Given this list of marker genes Pnoc, Ccl6, Agtr1a, Chrm1, Htr2a, Kiss1r, Edn2, Pomc, Chrm2 (NCBI Gene Id 243764), Cxcl13 (NCBI Gene Id 70783), Npb, P2ry6, Sstr3, Hcar1, Gpr143, Chrm5, Gpr65, Chrm4, Rxfp1, Opn5, Lpar4, Mtnr1b, Ltb4r1, Cysltr1, Fshr, Drd1, Oprl1, Npy1r, Rln3, P2ry13, Mc5r, Taar9, Qrfp, Ffar2, Ednrb, Adrb1, Adra2a, Ccrl2, Uts2r, Hrh2, Brs3, Nln, Ntsr1, Htr2c, Ppbp, Gpr37l1, F2r, Gpr35, Avpr1a, C5ar2 (complement component 5a receptor 2), Mc3r, Galr3, Qrfprl, Lpar5, Galr1, Rgr (NCBI Gene Id 57811), Cga, Cckbr, Cxcr4, Bdkrb1, Ccl3, Cxcl5, Oprk1, Gpr68, Psap, Xcl1, Oprm1, F2rl3, Tshr, Ptgfr, Ptger1, Lpar6, Gpr183, Pdyn, Trhr, Ptgdr2, Nmur1 (NCBI Gene Id 14767), Htr4, Gpr17, Oprd1, Mc4r, Npy2r, Tbxa2r, Sst, Cnr2, Xcr1, Ece2, Hcrtr2, P2ry2 (NCBI Gene Id 18442), Ptgir, Tac1, Sstr2, Drd4, Pf4, Ccr10, Opn3, Hrh1, Kng2, Tacr1, Ccl1, Ccl4, Grp, Hrh4, Cxcr5 (C-X-C motif chemokine receptor 5), Gpr18, Adra1d, Ltb4r2, Lhb, Hebp1, Prlh, Cxcr1, Ccl11, Npff, Npffr1, S1pr1, Rrh, Npsr1 (neuropeptide S receptor 1), Gpr31b, Htr1a, Ptger3, Tacr3, F2rl1, Adra2c, Gpr132, F2, Ccl17, Ccl21f, Avpr1b, P2ry1 (NCBI Gene Id 18441), Ccr5, Npffr2, Ccr6, Ptger4, Adra1a, Ccl25, Rho, Oxt, Bdkrb2, Lpar1, Grpr, Xk, App, F2rl2, Mtnr1a, Ccl9, Taar8b, Agtr2, Mc2r, Plppr5, Npy4r, Fpr-rs4, Insl3, Adora2b, Ccl27b, Prlhr, Edn1, Cxcr6, Taar1, Sucnr1, Hcar2, Adora3, Cxcr3 (NCBI Gene Id 12766), Opn1sw, Ccl21e, Plppr2, Avp, Kiss1, Mchr1, Ptger2, Tac2, Cnr1, Cxcl1, Prokr2, Drd5, Plppr1, Cxcl12, Ffar1, Npbwr1, Sstr1, Hc, Tacr2, Ppy, P2ry4, Lhcgr, Kel, Cx3cr1, S1pr5, Fpr-rs3, Ccl5, Htr2b, P2ry14, Ackr2, Fpr3, Cxcl2, Pyy, Cx3cl1, Gpr39, P2ry12, Adra1b, Aplnr, Gpbar1, Ptafr, Drd2, Sstr5, S1pr2, Hcrt, Nps, Cxcl9, Cckar, Ntsr2, Pmch, Ccl22, Fpr-rs6, Adrb2, Tshb, C3ar1 (NCBI Gene Id 12267), Uts2, Ccl27a, Mc1r, Ccl12, Ccl19, Gal, Htr7, Prok2, Gnrhr, Nmu, Taar8c, Apln, Oxgr1, Avpr2, Cxcr2, Nmb, Adora1, Lpar2 (lysophosphatidic acid receptor 2), Prokr1, Gpr37, Drd3, Plppr4, Uts2b, Gper1, Taar2, Ackr3, Npw, Cort, Rxfp3, Ackr4, Htr1b, Hrh3 (histamine receptor H3), Agt, Ccr9, Rxfp4, Ccr7, Plppr3, Ffar3, Gpr4, C3, Rln1, Trh, Nmur2, Nts, Opn4, Penk, Taar6, Ccr8, C5ar1, Ccl21b, Htr5a, Nmbr, Taar3, Cxcl10, S1pr4, Taar5, Galr2, Ccl21d (NCBI Gene Id 65956), Fshb, Ccr3, Hcrtr1, Cxcl16, Ece1, Htr1f, Gnrh1, S1pr3, Chrm3, Adora2a, Gpha2, Edn3 (NCBI Gene Id 13616), Cmklr1, Ccr4, Rxfp2, Ednra, Htr1d (NCBI Gene Id 15554), Sstr4, Ccl21a, Nms, Fpr2, Opn1mw, Htr6, Eef1ece2, Fpr-rs7, Npy5r, Ccl27al, Npy, Adra2b (NCBI Gene Id 11552, adrenergic receptor, alpha 2b), Cxcl11, Anxa1, Ccl28, Lpar3, Insl5, Gpr55, Oxtr, Ccl20, Cxcl3, Prok1, Gphb5, Adrb3, Fpr1, Ptgdr, P2ry10, Cck, Cysltr2 (cysteinyl leukotriene receptor 2), here is a description of the gene set: Class A/1 (Rhodopsin-like receptors) Mouse Gene Set: REACTOME_CLASS_A_1_RHODOPSIN_LIKE_RECEPTORS studied in species Mus musculus